Given this list of marker genes Atp1a2, Calr, Nfkb1, Chek2, Atp1a1, Rad51, Abcb1a, here is a description of the gene set: Mouse Gene Set: GOBP_RESPONSE_TO_GLYCOSIDE studied in species Mus musculus Any process that results in a change in state or activity of a cell or an organism (in terms of movement, secretion, enzyme production, gene expression, etc.) as a result of a glycoside stimulus.